The following is a description of a gene set: Genes predicted to be targets of miRBase v22 microRNA mmu_miR_181c_5p in miRDB v6.0 with MirTarget v4 prediction scores > 80 (high confidence targets). Mouse Gene Set: MIR_181C_5P from publication Chen Y, Wang X (PMID 31504780) species: Mus musculus, and this is the list of marker genes: Mpi, Pabir2, Tnf, Scyl3, Gpsm1, Tmed4, Gabra1, Qser1, Tcerg1, Togaram1, Bclaf1, Stim2, Zfp14, Zic3, Zfp970, Cdon, Rad21, Slc4a10, Cacnb2, Jade2, Zfp935, Gpd1l, Lrba, Ppp3r1, Lox, B4galt1, 1700066M21Rik, Sema4g, Zfp867, Ahnak, Jdp2, Lrrc32, Psap, Osbpl3, Nkain2, Pknox2, Cpeb4, Dnaja4, Zfp966, Klhl29, Cbfa2t3, Map4k4, Pou2f1, C2cd5, Zfp780b, Ccdc122, Ap4e1, Dido1, Nucks1, Zfp980, Rps6kb1, Zfp36l2, Htr1f, Esm1, Igdcc3, Nab1, Prkcd, Klhl42, Ddx3x, Pcdha9 (NCBI Gene Id 192161), Zfp965, Nfat5, Pcdha7, Spty2d1, Zfp934 (NCBI Gene Id 77117), Klf15, Zfp869, Mmp14, Ipmk, Trak1, Taok1, Crebrf, Gatm, Acvr2b, Acsl4, Gm14391, Mybl1, Lyrm1, Ap1s3, Tulp4, Rnf182, Zfp808, Rin2, Anapc16, Trim2, Sik3, Mtpn, Greb1l, Fnip2, Ncald, Hycc2, Rai1, Tbc1d4, Syne1, Pcdha12, N4bp2, 2010315B03Rik, Phlda1, Lin28b, Zbtb7a, Ipo8, Slc2a3, Hic2, Slc25a37 (solute carrier family 25, member 37), Cep97, Lhx9, Tmem165, Zfp781b, Zfp931, Zfp951, Rala, Dnajc21, Mycbp2, Lif, Cdc42bpa, Zfp619, Sin3b (NCBI Gene Id 69949), Klhl5, Nr3c1 (NCBI Gene Id 14815), Arl13b, Ercc8, Iqschfp, Crim1 (NCBI Gene Id 50766), Zfp101, Cbx7, Mlf1 (myeloid leukemia factor 1), Gm14326, Grik2 (NCBI Gene Id 320644), Epha4 (NCBI Gene Id 98323), E2f7, Zfp317, Tsc22d2, Slf2, Zfp810, Atp2b2 (NCBI Gene Id 22426), Adamts6, Slc25a36, Tns1 (NCBI Gene Id 98418), Nr4a3, Mtf2, Dio2, Gpr22, Epc2, Rufy3, Zdhhc7, Zfp458, Mfsd6, Tbc1d1, Gigyf1, Zfp850, Lclat1, Slc7a13, Btbd3, Scamp2, Naa15, Carf, Cpne2, Usp42, Bhlhe40, Ano1, Clasp2, Cfap90, Cdc40, Hsp90b1, Ssx2ip, Armcx3, Tgfbr1, Sfmbt1, Kcnq5, Dlg2, Cpd, Zfp120, Dock4, Htr1a, Pnisr, Plcl2, Dcbld2, Rsad1, Trim71, Ccnj, Esr1, Pcdha6, Pcdha5 (protocadherin alpha 5), Prdm4, Fign, Pcdha2, Grb10, Nwd2, Oxsm, Cnksr3 (NCBI Gene Id 215748), Hibch, Mdh1b, Tada2b, Il1a, Tnfrsf11b, Nr6a1, Kcnh1, Tmem94, Cnksr2, Lemd3, Larp4, Entpd6, Brd1, Ino80d, Glrb, Zfp976, Arf6, Thrb, Zfp960, Nek7, Usp33, Cluh, Aldh3a2, Lmo1, Zfp971, Ube2b, Golga1, Gm14322, Ap1g1, Zfp975, Bend3, Phf20l1, Rabgef1, E2f5, Pcdha1, Zfp1009, Ralgapb, Nus1, Zfp600, Patl1 (NCBI Gene Id 225929), Adamts5, Phtf2, Adamts1, Spry4, St8sia4, Specc1l, Creb1, Agfg1, Atxn1, Clec10a, Birc6, Nexmif, Clip1, Ttl, Trub1, Ubp1, Pdcd6ip, Hey2 (NCBI Gene Id 30802), Cyp2c39 (cytochrome P450, family 2, subfamily c, polypeptide 39), Atp2b1, Dusp6, Msantd3, Mb21d2, Umad1, Mideas, Drd1, Zfp280d, Prrc2c, Zfp930, Adcy9, Gskip, Ddx55, Smap1, D430041D05Rik, Rbm46, Rlim, Rex2, Sec24a, Rbm26, Zfp958, Gm14325, Fmnl2, Pcdha3, Etl4, Mtx3, Spink2, Kcna4, Zfp973, Sox6, Tnfsf10 (tumor necrosis factor (ligand) superfamily, member 10), Rassf1, Pax9, Jarid2, Prox1, Hoxa11, Atg5, Zdhhc17, Zfp36l1, Bcl2l11, Gm14296, Pcdha8, Itsn2, Ythdf3, Cpsf6, Zfp800, Xpo7, Adam11, Rorb, Carm1, Hipk3, Chic1, Pcdha11, Tent4b, Gm6710, Spire1, Spice1, Prtg, Hmbs, Ippk, Zfp1008, Slitrk1, Kmt2c, Ppip5k2, Gm20939, Cecr2, Ythdc2, Kmt2a, Pcdhac1, Pals1 (protein associated with LIN7 1, MAGUK family member), Prom2, Plekhj1, Morc3, Adamtsl1, Mamdc2, Zbtb41, Ncoa2, Peak1, Tab3, Sgpp1, Papolg, Grm5, H2-K1, Hoxc8, Clasp1, Pdap1, Gse1, Nr2c2, Slc35f3, Tmeff1, Ppfia1 (protein tyrosine phosphatase, receptor type, f polypeptide (PTPRF), interacting protein (liprin), alpha 1), Ago2, Rassf8, Gata6, Mfsd1, Esco1, Zfp967, Med8, Pcdhac2, Gpd2, Klf6, Mier3, Lrrc8e, Zfp936, Mturn, Ercc5, Wdr82, Cblb, Nova1, Dennd4c, Gls, Nipal4, Septin8, Heca, Pcdha4, Adarb1, Acvr1c, S1pr1, Rnf34, Zbtb43, Srsf7, Rnmt, Dnajc13, Ss18l1, Pcdha10, Gm6712, 5730507C01Rik, Fam3c, Sowaha, Tnfaip1, Atp2b3, Gfpt1, Tecpr2 (NCBI Gene Id 217862), 2210418O10Rik, Zfp97, Dlgap2, Hoxa1, Ccp110, Dclk1, Wsb1, Apba1, Eya3, Ptbp3, Zfp825 (zinc finger protein 825), P2ry10, Kpnb1, Schip1, Man2a1, Wnk1, Ankrd44, Baz2b, Ttpa, Palb2, Abi3bp, Zfp704, Tspan13, Stxbp6 (syntaxin binding protein 6 (amisyn)), Sec24c, Rps6ka3, Dram1, Ttc39b, Zbtb4, Rbbp7 (retinoblastoma binding protein 7, chromatin remodeling factor), Mboat2, Dmxl2, Zic2, Nmnat3, Pbx1, Cdyl, Cntn4, Mapk1, Pi15, Sim1, Txndc12, Pi4k2b, Abtb2 (NCBI Gene Id 99382), Fbxo33, Nr1d2, Limch1, Afg3l2, Etv6, Ubl3, Atf7ip2